Given this list of marker genes TMPO, SIRT2, LMNB1, LEMD2, LEMD3, PPP2CA, LMNA, BANF1, CDK1, KPNB1, CCNB2, PPP2R2A, LBR, VRK2, CCNB1, ANKLE2, VRK1, PPP2R1A, EMD, here is a description of the gene set: studied in species Homo sapiens Human Gene Set: REACTOME_INITIATION_OF_NUCLEAR_ENVELOPE_NE_REFORMATION Initiation of Nuclear Envelope (NE) Reformation